Given this list of marker genes Pik3r3, Pik3cb, Pik3cd, Yes1, Pik3r6, Lck, Pik3r1, Vav1, Akt3 (thymoma viral proto-oncogene 3, NCBI Gene Id 98462), Them4, Grb2, Akt1, Lyn, Cdc42, Ppp2r5c (protein phosphatase 2, regulatory subunit B', gamma), Mlst8, Pak2, Ppp2r5e, Ppp2cb, Rac1, Ppp2r5d (NCBI Gene Id 21770), Cd86, Rictor, Pik3ca, Pak3, Pik3r5, Trib3, Ppp2r5a, Cd80, Map3k8, Prr5, Ppp2r1b, Ctla4, Grap2, Akt2, Mtor, Ppp2ca, Ppp2r1a, Ppp2r5b, Cd28, Pak1, Src, Fyn, Pik3r2, Mapkap1, Pik3cg, Map3k14, Pdpk1, here is a description of the gene set: Co-stimulation by CD28 studied in species Mus musculus Mouse Gene Set: REACTOME_CO_STIMULATION_BY_CD28